The following is a description of a gene set: Triggering of B cell receptors (BCR) induces a massive synthesis of NFATc1 in splenic B cells. By inactivating the Nfatc1 gene and re-expressing NFATc1 we show that NFATc1 levels are critical for the survival of splenic B cells upon BCR stimulation. NFATc1 ablation led to decreased BCR-induced Ca++ flux and proliferation of splenic B cells, increased apoptosis and suppressed germinal centre formation and immunoglobulin class switch by T cell-independent antigens. By controlling IL-10 synthesis in B cells, NFATc1 supported the proliferation and IL-2 synthesis of T cells in vitro and appeared to contribute to the mild clinical course of Experimental Autoimmune Encephalomyelitis in mice bearing NFATc1-/- B cells. These data indicate NFATc1 as a key factor controlling B cell function. studied in species Homo sapiens Human Gene Set: GSE21063_WT_VS_NFATC1_KO_16H_ANTI_IGM_STIM_BCELL_UP from publication Bhattacharyya S, Deb J, Patra AK, Thuy Pham DA, Chen W, Vaeth M, Berberich-Siebelt F, Klein-Hessling S, Lamperti ED, Reifenberg K, Jellusova J, Schweizer A, Nitschke L, Leich E, Rosenwald A, Brunner C, Engelmann S, Bommhardt U, Avots A, Müller MR, Kondo E, Serfling E (PMID 21464221) Genes up-regulated in B lymphocytes stimulated by anti-IgM for 16h: wildtype versus NFATC1 knockout., and this is the list of marker genes: PHLDB3, PABPC4, CRYBB2, SIK1, LONRF3, APBB1, BLTP3A, AAR2, OSBPL5 (NCBI Gene Id 57656), OTUB1, PER1 (NCBI Gene Id 5187), USP16, CCNY (cyclin Y), DNAJB1, SLBP, MAPKAPK2, IKZF5, RBM38, MUL1, ANAPC10, CDK12, SMOC2, ITGAM, SUSD1, CHKA, PLK3, ITCH, REXO1, PIP4P1, SLC2A1, ID1, EDC4, PELI2, ZBTB49, CDK5RAP1, TRIM39, DNAJC18, TNFRSF10B, DDX19B, STX1A, BCL6, SLC41A3, CTPS1, RNF115, ABO, ZBTB2, FBXO32, H2BC8 (H2B clustered histone 8), TRAF3IP2, BCOR, CSNK1E, HUS1, CRY2, BAMBI, KLHL24, KCNK7, BLVRB, SNX30, SUPV3L1, TIGAR, BRD1, RELT, IRAK1, IDI1, PIAS2, PRXL2C, FAM169A, GADD45A, OXA1L (OXA1L mitochondrial inner membrane protein), NRIP3, WDFY1 (NCBI Gene Id 57590), NDUFAF5, MALT1, LMBR1L, ITPRIP, LDB1, SRRD, ANKRD13D (ankyrin repeat domain 13D), TBC1D23, NUP54, RMC1, ADNP2, ATG2A, MTMR6, DGKD, BAZ2A, PLEKHF1, BCL9L, TGFB1, CACNA2D2, LILRA4, USP3, ACSL1, TEX14, SMURF1, MKRN2, PRKCB, MACO1, ETNK2, MAIP1, MOB3B, H2AC25, SNHG17, DNMBP, FAH, TUBA4B, NUP58, CORO7, RHOF, IL18BP, SIRT1, ADAM9, CHST10, RB1CC1, ABL1, PIGT, ACVR1B, GMEB2, ZNF484, ITPR3, USP14, BTBD9, PXN, PLBD1, MAP2K7, CCDC157, DNAJA4, UAP1, APOE, H2AC4, BRMS1L, ISCA1, ASB6 (NCBI Gene Id 54975), ZNF331, ZYG11A, GRM2, RAP1GAP2, TSC22D3, UBAP2L, YAF2, PRG2, RGCC, HES6, USP30, MTMR14, ALG9, SPON2, ZBED4, KIF21B, GYPC, VPS11, PTTG1, ITGA5, RAB30, MED26, TUFT1, IPO5, HHEX, PPM1A (protein phosphatase, Mg2+/Mn2+ dependent 1A), AGO2, SPOCK2, ZNF90, ATP2B1, SNRK, UBE2O, STOML3, SNHG8, IQSEC1, PTPRE, CHEK1, TRIP6, NSMF, XPNPEP2, CDS2, ELL2 (NCBI Gene Id 22936), ENSG00000261327, ARHGEF7, ULK1, TIAL1, ATG9A, CCT6B, PRC1, RNF125, TUBA3D (NCBI Gene Id 150778), GNL1, MIDEAS (NCBI Gene Id 91748), PTP4A1, TUBA4A (NCBI Gene Id 93373), TADA2B, FAM117B, FOXK2, ELL, MXD4, PGM3, TSPAN14, CXCR1, LANCL2, HSPA13